The following is a description of a gene set: studied in species Mus musculus Signaling by GPCR Mouse Gene Set: REACTOME_SIGNALING_BY_GPCR, and this is the list of marker genes: Ccr5, Gna14, Lpar1, Gpr150, Rgs20, Ghrl, Net1, Chrm1, Mapk1, Gpr45, Cnr2, Rgs17 (NCBI Gene Id 80505), Mc2r, Plcb2, Cysltr1, Ednra, Gnai1, Ptafr, Ltb4r2, Rps6ka3, Qrfp (pyroglutamylated RFamide peptide, NCBI Gene Id 227717), Cxcl5, Ntsr1, Opn5, Sos2, Tas2r130, Sstr3, Ppp2r5d, Btk, Rgs9, S1pr2, Ghrhr, Ppp2cb, Adm2, Tacr2, Arhgef33, Ffar3, Pde4d (NCBI Gene Id 320753), Ccl5, Glp2r, Dgkq, Tas1r2, Opn1sw, Fpr3, Ppp2r1b, Rgs14, Hrh3, Gpr39, Ccr10, Rhoa, Crhr2, Taar3, Gpbar1, Npffr1 (NCBI Gene Id 237362), Avp, Arhgef3, Grb2, Vipr1, Adrb3, Kras, Pyy, Cxcl10, Ccl28, Gng7, Pde3a, Itpr3, Lpar2, C3, Arhgef19, Tas2r144, Gng4, Ccl20, Itpr2, Tac2, Opn3, Prkcd, Gpsm1, Fpr-rs3, Eef1ece2, Adcy5, Grp (NCBI Gene Id 225642), Gip, Tas1r3, Gpr15, Prkch, Tacr3, Ccr4, Taar8b, Pnoc, Grm1, Rgs19 (NCBI Gene Id 99397), Cxcr3, Avpr1b, Cga, Ccl21b, Sst (somatostatin), Xcr1, Pdyn, Lpar5, Gpr83, Calm1, Ccl3, Adgre5, Gnb1, Grm6, Rxfp3, Nts, Pde2a, Htr1f, Cck, Htr1b (5-hydroxytryptamine (serotonin) receptor 1B), Trpc7, Tas2r108, Sos1, Gal, Ackr3, Ccl22 (C-C motif chemokine ligand 22, NCBI Gene Id 234578), Lhcgr, Grm7, Rgs18, C5ar2, Ccr3, Akt2, Pf4, Plppr4, Itsn1 (intersectin 1 (SH3 domain protein 1A)), Htr6, Htr4, Penk, Ptgdr, Dgkh, Mc5r, Nps, Gng3 (NCBI Gene Id 14704), Hcrtr2, Npy, App, Rrh, Galr3, Rgs21, Gnaz, Grm4, Htr5a, Tas2r121, Fgd4, Sctr, Nmu, Sucnr1, Gng8, Dgka, Lpar6, Avpr1a, Arhgef15, Sstr1, Avpr2, Prlhr, Dgkd, Prkcq, Calcb, Arhgef10l, Grk2, Hc, Ptgir, Ccl19, Ppp1r1b, Arhgef1, Rgs3, Gast, Calca, Ccr6, Gpr176, Vip, Fpr1, Nmur2, Prkcg, S1pr5, Gper1, Ccl12, Cxcl2, Edn3, Ffar4, Arhgef18, Pde7b (phosphodiesterase 7B), Gna12, Lhb, Gng11, Arhgef17, Mc4r, Cx3cr1, F2r, Pth, Abr, Pthlh, Gpha2 (NCBI Gene Id 170458), Pik3ca, Pde4a, Dagla, Edn1, Cx3cl1, Arhgef7, Dgkk, Iapp, Grm5, Hcar1 (NCBI Gene Id 243270), Shc1, Cckbr, Mgll, Sstr5, Htr1a (NCBI Gene Id 15550), Prok1, Ccl4, Vipr2, Rln1, Adcyap1, Kalrn, Rgs5, Ccl25, Rps6ka2, Adora3, Plcb4, Prkce, Fpr-rs4, Dgkg, Cxcl9, Lpar4, Insl3, Calm2, Gnrh1 (NCBI Gene Id 239161), Cxcr5, Opn4, Gpr37l1, Tas2r118, Brs3, Npy4r, Grk3, Itgb1, Dgke, Arhgef6, Gabbr2, Plppr1, Adrb1, Agt, Pcp2, Nln, Tas2r120, Tas2r126, Rgs16, Gphb5, Gng5, C5ar1, Adra1a, Tas1r1, Trpc3, P2ry10, Tas2r140, Cxcl13, Uts2r, Arhgef5, Pth2r, Rln3, Plxnb1, Gna11 (NCBI Gene Id 327779), Mc1r, Galr2, Adcy8, Ccl9, Prkaca (NCBI Gene Id 18747), Drd4, Ccl21f, Fgd2, Chrm5, P2ry1, Mtnr1b, Cdc42, Tiam2, Adra2c, Grk6, Grpr, Pde1b, Ccr7, Ngef, Mcf2l, Prok2, Rps6ka1, Mcf2, Tas2r131, Gnat3, Pdpk1, Calcr, Plcb3 (phospholipase C, beta 3), Gnaq, Ptger1, Gng2, Rgs12 (NCBI Gene Id 77052), Calm3, Gnal (NCBI Gene Id 72463), Ramp2, Gnat1, Ece1, Akt3, Hcrt, Pde7a, Ppy, Tas2r137, Ramp1, Gipr, Chrm4, Trio, Fshb (follicle stimulating hormone beta), Ppp1ca, Anxa1, Npw, Oxgr1, Cxcr4, Adrb2, Cxcl16, Ccrl2, Adcy3, P2ry12, Ccl27al (C-C motif chemokine ligand 27A like), Drd1, Akap13, Plcb1, Ccl27b, Ednrb, Adra1b, Taar6, Kiss1, Gpr25, Tshb, Ccl1, Trpc6, Rgs4, Dgki, Arhgef12, Adora1, Arhgef2, Ltb4r1, Rho, Tacr1, Cckar, Pik3r6 (phosphoinositide-3-kinase regulatory subunit 5), Cysltr2, Gngt1, Vav1, Cxcl12, Nmb (NCBI Gene Id 68039), Gpsm3, Uts2, Fpr2, Adra2a, Chrm3, Gna13, Ackr4, Htr1d, Calcrl, Ccr1, F2rl1, Pla2g4a, Rgs11, Plppr3 (phospholipid phosphatase related 3), Daglb, Opn1mw, Gnai2, Pik3r1, P2ry14, Gpr55, Rgsl1, Kel, Uts2b, Oprl1 (opioid receptor-like 1), Hcar2, Adcy9, Pomc, Fpr-rs6, Gabbr1, Prokr2, Dgkb, Adcy4, Ghrh, Oprk1, Fn1, Adm, Gpr35, Gng13, Hras, Adcy7, Prlh, Hebp1, Adra1d, Gnrhr, Cxcl11, Apln, Fgd3, Pik3r2, Gnas, Ppp2r1a (protein phosphatase 2, regulatory subunit A, alpha), Taar5, Hrh2, Gpr143, Oxt, Prokr1 (prokineticin receptor 1), Itga5, Gpr68, Vav2 (vav 2 oncogene), Oxtr, Gnb2, Cmklr1, Cxcl3, Tas2r135, Arhgef25, Gpr65, Htr2a (NCBI Gene Id 239184), Dgkz, Pde1a, Creb1, Qrfprl, Pth2, Cxcr1 (NCBI Gene Id 227288), S1pr4, Abhd6, Npff, Adcy6, Agtr2, Obscn, Grm3, Ucn2, Taar9, Cxcl1, Ghsr, Mchr1, Src, Tas2r106, Gprc6a (G protein-coupled receptor, family C, group 6, member A), Ccl21d, Pmch, Arrb1, Ppp2ca, Tbxa2r, Fshr, Gng10, Gpr37, Rgs8, Rgs1, Prex1, Drd3, Gpr20, Ccr8, Lpar3, Pde8a, Ccl21a, Ppbp, Ccl11 (NCBI Gene Id 20292), Ptger4, Ect2, Akt1, Edn2, Agtr1a, Sct, Rxfp1, Casr, Kng2, Hrh4, Nmur1 (NCBI Gene Id 14767), Oprm1, Arhgef11, Ptger3 (prostaglandin E receptor 3 (subtype EP3)), Gpr4, Gng12, Xcl1, Tas2r138, Npsr1, Npy1r, Abhd12, S1pr3, Itpr1, Tas2r136, Sstr4, Npbwr1, Rock1, Pde1c, Arhgef10, Ptgfr, Camkk1, P2ry4, Pth1r, Pak1, Ccl17, Ece2, Plppr5, Adora2b, Ucn, Crh, Adcy1, P2ry2, Tas2r139, Bdkrb2 (NCBI Gene Id 12062), Gpr18, Mapk7, Rgs2, Htr7 (5-hydroxytryptamine (serotonin) receptor 7), Gpr132, Crhbp, Gcgr, Gnb5, Fgd1, Rock2, Ucn3, Arhgef26, Arrb2, Tac1, Gna15, Prkar1a, Rgs7, Plekhg5, Ffar1, Arhgef16, Ackr2, Grk5, Adcy2, Ccl21e, Cd55, Gnat2, Chrm2, Psap, Cxcr6, Insl5, Htr2b, Taar8c, Gcg, Egfr, Arhgef9, Ccl6, Gpr84, Pde4c, C3ar1, Pde8b, Aplnr, Trh, Galr1, Gpr31b, Crhr1, Plekhg2, Gngt2, Prkacb, Gnb4, Mtnr1a, Rxfp2, Ptger2, Pik3r5, Cdk5, Xk, Taar1, Mc3r, F2rl2, Ntsr2, Adora2a, Rasgrf2, Nms, Hcrtr1, Ccr9, Drd2, Cxcr2, Rhoc, Drd5, S1pr1 (sphingosine-1-phosphate receptor 1), Grm2, Vav3, Pik3r3, Taar2, Ptgdr2, Adra2b, Gpr27, Cnr1, Ffar2, Tshr, F2, Adcyap1r1, Npffr2 (NCBI Gene Id 56056), Trhr, Rgr, Fpr-rs7, Plppr2, Kiss1r, Nmbr, Gnai3, Rhob, Gpsm2, Rxfp4, Ccl27a, Hrh1, Pde10a, Htr2c, P2ry13 (purinergic receptor P2Y, G-protein coupled 13), Camkk2, Mapk3, Prkar1b, Pde4b, Cort, F2rl3, Hbegf, Arhgef39 (Rho guanine nucleotide exchange factor 39), Npy2r, P2ry6, Npb, Ramp3, Gpr183, Glp1r, Bdkrb1, Rgs6, Rgs13, Pde11a, Npy5r, Mmp3, Arhgef37, Tas2r119, Grm8, Arhgef38, Sstr2, Oprd1, Gnb3, Adgre1, Gpr17, Pik3cg